The following is a description of a gene set: Human Gene Set: GOBP_POSITIVE_REGULATION_OF_VASCULAR_ASSOCIATED_SMOOTH_MUSCLE_CELL_PROLIFERATION Any process that activates or increases the frequency, rate or extent of vascular smooth muscle cell proliferation. species: Homo sapiens, and this is the list of marker genes: P2RY6, MEF2D, MIR20A, GJA1, MIR21, HTR1B, MIR17, FGF2, MIR221, MIR222, RGCC, NF1, MIR208A, FGF9, GNAI2, CALCRL, PDGFB, ADAMTS1, MAP3K7, MAP3K5, XBP1, DNMT1, MIR135B, MIR214, IGFBP5, MIR499A, MIR448, HPGD, JAK2, ERN1, LDLRAP1, DDR2, MMP2, EDN1, TNF, MFN2, IL10, BMPR1A, MMP9, FGFR2, PAK1, MIR27A, MIR27B, FOXJ2, MDM2, MIR146A, NR4A3, IGF1, MIR301A, JUN, MIR26A1, TERT, MIR130A